The following is a description of a gene set: studied in species Homo sapiens A reduced concentration of calcitriol in the blood. Calcitriol is also known as 1,25-dihydroxycholecalciferol or 1,25-dihydroxyvitamin D3. Low serum calcitriol Human Gene Set: HP_LOW_SERUM_CALCITRIOL, and this is the list of marker genes: CYP2R1, CLDN16 (NCBI Gene Id 107986170), CYP3A4, DMP1, LRP5, CYP27B1, ENPP1